The following is a description of a gene set: Human Gene Set: GOMF_HISTONE_H4K12_ACETYLTRANSFERASE_ACTIVITY Catalysis of the reaction: acetyl-CoA + histone H4 L-lysine (position 12) = CoA + histone H4 N6-acetyl-L-lysine (position 12). studied in species Homo sapiens, and this is the list of marker genes: ING4, JADE1, KAT2A, BRPF3, KAT6A, KAT7, BRPF1, ING3, BRD1, JADE2, MEAF6, HAT1